The following is a description of a gene set: Reactome Pathway: IRS-mediated signalling electronically inferred by orthology from the curated human pathway This event has been computationally inferred from an event that has been demonstrated in another species.<p>The inference is based on the homology mapping from PANTHER. Briefly, reactions for which all involved PhysicalEntities (in input, output and catalyst) have a mapped orthologue/paralogue (for complexes at least 75% of components must have a mapping) are inferred to the other species. part of: IRS-related events triggered by IGF1R; Insulin receptor signalling cascade studied in species Mus musculus, and this is the list of marker genes: Fgf10, Fgf6, Irs2, Klb, Tlr9, Frs2, Irs1, Fgf23, Gab1, Pik3c3, Fgf7, Fgf8, Fgf2, Fgf20, Fgf4, Fgf16, Pdpk1, Pik3cb, Kl, Them4 (thioesterase superfamily member 4), Fgf15, Fgf22, Grb2, Fgf5, Fgfr1, Fgf17, Flt3l, Fgf1, Pik3r2